Given this list of marker genes Atp1b2 (ATPase, Na+/K+ transporting, beta 2 polypeptide), Atp1b3, Atp1a3, Atp1a4, Atp1b1, Atp4b, Atp1a2, Atp1a1, Atp4a, Cpox, Atp12a, here is a description of the gene set: Mouse Gene Set: GOMF_P_TYPE_POTASSIUM_TRANSMEMBRANE_TRANSPORTER_ACTIVITY studied in species Mus musculus Enables the transfer of a solute or solutes from one side of a membrane to the other according to the reaction: ATP + H2O + K+(out) = ADP + phosphate + K+(in).